The following is a description of a gene set: Mouse Gene Set: MIR_6374 studied in species Mus musculus Genes predicted to be targets of miRBase v22 microRNA mmu_miR_6374 in miRDB v6.0 with MirTarget v4 prediction scores > 80 (high confidence targets). from publication Chen Y, Wang X (PMID 31504780), and this is the list of marker genes: Col4a3, Tmem263, Sptlc2, Mbtps1, Csrnp3, Mbtd1, Erbb4, Pop1, Galnt3, Tpm1, Ccdc112, Nxt2, Lancl3, Rhoa, Senp7, Hopx, Tiparp, Tnrc6b, Shisa6, Sgip1, Sorcs3, Cenph, Cdyl, Pcdh20, Dip2a, Rtn1, Marchf2, Fhip2a, Acsl4, Txlnb, Samd8, Ccdc18, Isy1, Fam76b, Fbxw7, Fndc3b, Ercc6l2, Pik3c2a, Pclo, Mapkbp1, Cfap97, Dlg2, Pwwp3b, Cmah, Edn2, Napepld, Stc1, Bmp4, Rp2, Fam91a1, Slc6a20b, Slc25a33, Ubald2, Zbtb44, Spag16, Zfp354c, Pak2, Nid1, Ythdf3, Eloc, Kctd5, Gabra1, Amacr, Gabra2, Zc3h6, Ark2c, Rmnd5b, Cxcl9, Gpr171, Cpne8 (copine VIII), Tmtc2, Cep135, Ankrd27, Myt1l, Rnh1, Rab11fip2, Mcm3, Zic3, Ism1 (isthmin 1, angiogenesis inhibitor), Sumo2, Zdhhc17, Pip4p1, Prxl2c, Abcd4, Abca14